The following is a description of a gene set: Human Gene Set: GOBP_DEFENSE_RESPONSE_TO_OTHER_ORGANISM species: Homo sapiens Reactions triggered in response to the presence of another organism that act to protect the cell or organism from damage caused by that organism., and this is the list of marker genes: TRIM54, IFNL1, DTX3L, NLRP1, DEFB108B, CNPY3, BPIFB1, UAP1, CXCL10 (C-X-C motif chemokine ligand 10), IRF7, NTS, SRPK1, ZBTB1, LRRC19, TRIM51, IGHA1, TRIML1, RAET1E (retinoic acid early transcript 1E), TNFSF4, HLA-E, GARIN5A, YTHDF3, CSF1, IL31RA, KYNU, SELP, METTL3, TRIM27, NPLOC4, HAVCR2, SMARCA5, CCL17, CCL11, SYT11, CCL24, S100A9, VIP, VPS26B, MIR19A, LEP, IFNK, SLAMF6, RFPL1, VGF, RAB27A, IFITM3, LGALS9, CD200, NLRC3, CXCL2, PGLYRP2, BIRC3, RAB20, GPR146, PGLYRP3, RNF34, IFNE, TRAFD1, INS, JAK2, FBXL2, TUSC2, TRIM64B, LILRB1 (leukocyte immunoglobulin like receptor B1), CCL21 (NCBI Gene Id 6366), CHUK, LPO, LCE3C, APPL2, POLR3F, CFH, CD160, KIR2DS2, WFDC3, MARK4, UNC13D (NCBI Gene Id 201294), CD6, N4BP3, IFNA7, MEFV, CCL27, ADAMTS4, CR1, AP3B1, TREM2, DEFB121, GBP1, IFITM2, C4BPA, C4B, PELI3, ACTG1, WFDC9, PTX3, CD300E, REG1B (NCBI Gene Id 5968), FCER2, IFNL3, BIRC2, OPRK1, TTLL12, ATAT1, HSPD1, EPRS1, ARHGEF2, SERPING1, FGL2, PPP2R3C, NCR3, ZDHHC11, ILRUN, CAMK2A, USP15, FOSL1, CDC42EP2, IFNA4, DDX3X (NCBI Gene Id 730543), NFKB1, DDX17, EIF2AK2, CADM1, TRAV27, ITGAX (integrin subunit alpha X), HCST, DEFB125, ATG5, CHGA, GBP3, CCL20, CAMP, RAB11FIP2, MICB, EP300, KLRF2, SCNN1B, NAGLU, USP17L2, GATA6, RAB14 (NCBI Gene Id 51730), HK1, KNG1, IL27RA, VAMP2, TRIL, RFPL2, FFAR2, TBK1, CD96, CCL8, CCL25, DDX56, EREG, LCE3B, LATS2, SERINC5, TYK2, XCL1, CREB3, CD300LF, TRIM4, SUSD4, CDC37, TMEM43, BECN1, ANXA3, RNF135, ELANE, UBE2N, HRAS, PUM1, TMEM33, LRCH4, HMGB1, CLEC4M, LATS1 (large tumor suppressor kinase 1), HERC5, XCL2, AGBL5, KLRB1, CCL3, PF4, PRSS3, HLA-DPA1, F12, MYD88, KLRG1, UBE2L6, PLEKHM2, IFIT5, CD2, TARBP2, IFI6, RNASE3 (NCBI Gene Id 6037), IFNA21, DRD2, JAK1, STAT5A, IL17RA, XRCC5, CPT1A, IRF1, CARD8, CXCL8, TRIM6, NLRP10, LYST, IL27, DEFB1, ARG1, GRAMD4, NCBP3, PLSCR1, SRPK2, FCN2, RFPL4A, DCST1, COTL1, PPT1, DAPK3, IFNW1, OAS3, SHFL, GPAM, RFPL4B, TRIM14, FADD, TRAF3IP2, INPP5D, TREX1, MAP3K14, TLR8 (toll like receptor 8), IFI27, ZMPSTE24, SLAMF8, TRIM43B, DEFB136, RPS6KB1 (ribosomal protein S6 kinase B1), STING1, SAMHD1, TIFAB, TRIM49B, IL21, UBE2W, NCBP1, CD55, MIR149, DEFB131B, GNLY, TNIP1, DDIT4, CRTAM, TOMM70, CDC42EP4, C1QB, FCRL3, TLR9 (toll like receptor 9), PIK3CB, ZMYND11, UBE2K, TRIM58, TRDV1, ULBP3, IL17RC, LAMP2, DEFB124, CEBPB, IKBKE, CD1D, MED1 (mediator complex subunit 1), CLEC4C (NCBI Gene Id 63328), MIR200B, TRIM7, C5AR1, RBM47, ADAM15, G3BP1, PRTN3 (proteinase 3), ZDHHC4, NLRX1, PIK3AP1, DEFB107B, DEFB114, KLRC4 (NCBI Gene Id 8302), BPI, IL36RN, MR1, ANG, VNN1, BNIP3L, TREM1, TRIM52, ABCC9 (ATP binding cassette subfamily C member 9), CD300C, PYDC1, TRIM55, IFNA10, OAS2, CXCL11, NMB, APOBEC3G, FCER1G, KLRC1, PLCG2, TRIM32 (tripartite motif containing 32), VAPB, APOBEC3A, PHB2, NQO1, CD274, IRF3, AXL, CLEC2A, CXCL12, NFKBIA, IPO7, GSDMC, LALBA, CX3CR1, CCL18, IGHG4, OGT, STXBP3, CYLD, AKAP8, PYCARD, CASP1, PAK3, CFP, DHX15, CR2, LGALS8, SQSTM1, SLC11A1, SLC15A3, TRIM40, S100A7, TRIML2, LYG2, SLAMF1, ACOD1, CD244, IFI44L, MNDA, DEFB129, ANKRD17, ZYX, IL15, IRAK3, PLAC8, DEFB131A, ZNF175, CFHR5, INAVA, CFB, IFNA8, VSIG4, H2BC10, LYPD8, LILRA5, ELP6, MX2, FOXP1, MUL1, TYRO3, PF4V1, OAS1, CD300A, MIR20A, TBKBP1, EDN1, TRIM25, CXCL1, LACC1, SIRPA, DEFB105A, FCGR3A, HLA-A, LGALS4, H2BC12, DEFB134, NLRP6, CD84, TRIM68 (NCBI Gene Id 55128), LEAP2, REG1A, TMEM120A, H2BC12L, CLDN1, NPPB, IFNA17 (NCBI Gene Id 3451), KIR3DL1, RPL39, REL, SPINK5, BCL2, GBP2, SMPD1, CXADR, VAMP4, TREML4, C4BPB, PTPRS, CCL7, PPBP, MST1R, TAC1, RIOK3, ZDHHC11B, DEFB135, STMP1, MAP2K6 (NCBI Gene Id 5608), STX8, DEFB110, CCL19, NCF2, AQP1, VAV1, ZDHHC5, SPAG11A, SMIM30 (small integral membrane protein 30), TRIM74, CFI, TRIM48, NOP53, TNFRSF1A, PRKDC, TUBB4B (NCBI Gene Id 10383), NCK1, MATR3, KLRC4-KLRK1, PIK3R1, GBP4, MAP3K7, AIF1 (allograft inflammatory factor 1), TYROBP, TRGV3, MAPK8, IL36A, MIR210, TRIM64, ZC3H12A, DNAJA3, PIK3CD, CASP8, PLA2G10, GPR108, TARM1, VAMP3, TRIM63, ERAP1, ZNFX1, GPR15LG, SLC9A9, CEP63, CGAS, KCNJ8, NLRC4, BST2, SEC14L1, NT5C3A, HSP90B1, TRIM35, CD58, SERPINB4, STAB2, PLPP6, RELA, POLR3D, IGHA2, LILRA4, HP, CORO1A, APOL1, KIF5B, UBD, MMP7, LRRC14, KLRF1 (killer cell lectin like receptor F1), PRF1, NLRC5 (NCBI Gene Id 84166), CRISP3, DNAJC3, TRIM61, IL23R, JCHAIN, CCL5, CXCL3, TLR6, MIRLET7I, C6, NEDD4, SFTPD, DUS2, MID2, KCNK6, CCL3L3, TRIM3, GBP7, CALCA, PYDC2, PMAIP1, CCL28, LCN10, APOBEC3F, LY6E, CLEC7A, AZI2, IFNA2, ARID5A, XIAP, PCYOX1L, RPL13A, RFTN1, HLA-C, PLA2G2F, C1RL, CASP4, WFDC13, CALHM6, PTPN11, NR1H3, IL36B, FGA, RNASEL, TRIM13, LYZL6, HDAC4, IFITM1, C1R, HSPA1B, CTSS, TGFB1, WFDC12, DEFA1 (defensin alpha 1), RNASE12, HEXIM1, POLR3G, CX3CL1, CD209, ATG12, MIF, ADM, ZNRF1 (NCBI Gene Id 84937), TASL, MAVS, IFI35 (NCBI Gene Id 3430), PRKCD, ENDOD1, ADAM8, RBCK1, MRC1, SIGLEC10, SP100, RAG2, PARP1, TSLP, RNF216, PPP6C, PUM2, FLOT2, TRIM50, MIR140, PPP1R14B, DEFB104A, SFPQ, RASGRP1, SLC30A8, ZDHHC12, VIM, RAB43, SEMG1, TRIM26 (tripartite motif containing 26), DEFB108A, RNF170, TRIM77, WASHC4, SKP2, DEFB130A, IL33, PTPN2, DEFB4A (NCBI Gene Id 1673), IL1B, UBA7, RTN4, RNASE2, PELI1, FPR2, DEFB109B, NFE2L2, CLEC6A, EPG5, CFD, CASP7, NFKBIL1, CLEC12B (C-type lectin domain family 12 member B), MIR520B, GKN2, FLOT1, SERPINE1, TRIM65, TREML1 (triggering receptor expressed on myeloid cells like 1), LY86 (NCBI Gene Id 9450), USP44, RNASE13, WFDC10A, HMGB2, TOR2A, ADAMTS5, MPO, CTSG, NCR1 (natural cytotoxicity triggering receptor 1), LRSAM1, CSF1R, MMP12, POLR3E, DEFB103A, DEFB116, ITCH, LY96, LCN2, TRIM5, LSM14A, NLRP4, RPS6KA3, PARP14, UFD1, CXCL9, STX4, CEBPG, TRIM49C, PJA2, ARRB2, HLA-F, CCL16, KLK7 (kallikrein related peptidase 7), PARP9, CYP27B1, ATG7, JAGN1, ATG9A, IFNB1, STATH, SPN, TMEM106A, TSPAN6, PADI4, SIN3A, LYG1, DAPK1, H2BC6, TRIM49, YWHAE, CYBB, CCL23, SIGLEC16, NPY, PI3, EXOC1, AIM2, SLC30A1, TRAF6, SELENOK, PGC, KRT16, KAT5, CCL4, ELMOD2, ATP1B1, IFNA6, POLR3C, SPSB3, DEFB106B, GSDMB, DEFB128, HCFC2, DEFB133, ULBP2, MLKL, HSPA8, CD36, SARM1, MASP1, ITGAM (NCBI Gene Id 3684), EMILIN2, SLC15A4, CRK, PYDC5, RNASE8, PSTPIP1 (NCBI Gene Id 9250), H2BC4, TLR10, P2RX7, SDHAF4, S100A12, CD40, NEURL3, ATAD3A, CITED1, GZMM, MIR26B, EVPL, TNIP2, SNX3, DEFA4, PIK3R6, RARRES2, TRGV8, LRRC15, EPPIN, MFHAS1, IFNL2, SCARA3, IFNG, LYZ, CASP6, CST11, BANF1, GZMB, NR1D1, TRIM22, PDE12, IRF5, TMEFF1, VAMP7, RIPK3, IFI16, TNFAIP3, IFIT1B, RFPL4AL1, C8G, TRIM23, IFNA1, TFEB, CYBC1, MMRN2, DEFB126, TRIM11, TTC4, DHX36, USP38, ZDHHC18, ZCCHC3, DEFB127, CD37, CD226, RNASE7, CD177, IL1RL2, ACTR3, CXCL5, FCAR, APOBEC3D, PLA2G2A, SRC, SPAG11B, MASP2, MMP3 (NCBI Gene Id 4314), CALCOCO2, BSPRY, NKG7, HTN3, AKAP1, TRAF3, C1QA, XRCC6, TRIM29, TUBB, BNIP3, HYAL2, RAET1G, POLR3H, GFI1, CCL15, H2BC8, ARG2 (NCBI Gene Id 384), POLR3B, USP27X, IL1RAP, TRIM49D1, MOV10 (Mov10 RNA helicase), NOD2, BRCC3, ZDHHC1, RNASE1, IL6R, MIR520E, TRIM44, H2BC21, TF, MAPKBP1, LCE3A (NCBI Gene Id 353142), IRGM, TRIM72 (tripartite motif containing 72), NLRP9, ADAR, CPTP, RNF31, ISG15, STAT2, PTPN6, PQBP1, CXCL14, CLNK, DEFA1B, STXBP2, CD14, MIR17, C5, CST9LP1, RIPK2, RAF1, TMEM126A, CH25H, HMGN2, WFDC5, CD207, DEFB118, LGALS3, FOSL2, APOBEC3B, KLK3, TRIM49D2, RBPJ, ZG16, HPX, PTPRC, NONO, CXCL16, IL12A, RAB7B, IKBKB, TKFC, PLA2G5, ALPK1, MARCO, GSDMA, SLC22A5, PCBP2, HMGB3, ANXA1, SCIMP, DEFB103B, SPIRE1, EIF4E2, CLEC4A (NCBI Gene Id 50856), DTX4, MIR4691, TNFSF8, TRIM15, CLEC4E, DDX60, CD300H, IL6, LBP, BPIFB3, TRIM75, DUSP10, USP14, LY9, KLRK1, BATF, DDX39A, PGLYRP1, OTUD4, GRB2, KRT1, IFNA16, RNF125, ACP5, MIR21, CXCL6, LYAR, F2RL1, SETD2, NMI, DEFB107A, RNASE6, ADAM17, GSDMD, DEFB115, KLRC2, EXOSC5, BATF2, NR1H4, MARCHF5, SFN, GPS2, PRDM1, PVR (NCBI Gene Id 5817), CLEC5A, DDX41, FOXP3, PRSS2, RNF185, DEFB106A, TAB2, LILRA2, STXBP4, RNASE10, AURKB, BPIFA2, TXK, EMILIN1, TRIM41, IL22RA1, ULBP1, NEK7, DEFB105B, TRIM59, PYHIN1, MIR181B1, ECSIT, CD47, ERCC6, FGB, TICAM1, HSP90AA1, C1S, CLPB, N4BP1, KLRC3, AKT1, DEFA3, ABCF3, S100A8, CNOT7, PAK1 (p21 (RAC1) activated kinase 1), CYBA, FCN3, SHARPIN, CCL14 (C-C motif chemokine ligand 14), IL18RAP, USP20, SEH1L, HLA-B, CLEC4D, WNT5A, CFHR1, SEMG2, IL17F (NCBI Gene Id 112744), DCD, RNASE9, MIRLET7B, TRIM43, CCDC88B, OASL, NINJ1, PLD4, TRAF2, AIMP1, HVCN1, TRAF3IP3, PPP2CA, CRIPTO, FBXO9, CCL13, IFNL4, IGHG1, PGLYRP4, RSAD2, IL10RB, AKIRIN2, H2BC11, OPTN, USP29, TSPAN32, IGKV3-20, MYO1C, TLR5, UBL7, IFNLR1, PDPK1, PTPN22 (protein tyrosine phosphatase non-receptor type 22), CRP, GDI1, GSN, PPM1B, LRP8, NT5C2, TRGV5, BCL2L1, COLEC11, NUB1 (negative regulator of ubiquitin like proteins 1), PLA2G6, CDC42, SENP7, GPATCH3, C7, MAP4K2, TRIM21, MPEG1, TANK (NCBI Gene Id 10010), MUC7, MSRB1, FCGR1A, RPSA, HRG, DDX21, IKBKG, NDUFAF4, NLRP2, IL10, SYNCRIP (synaptotagmin binding cytoplasmic RNA interacting protein, NCBI Gene Id 10492), HSPA1A, ZNF697, TRIM38, POLR3A, RPS19, TRIM10, LGR4, TNFAIP8L2, IFNGR1, AP1G1, APP, CCL22, NLRP2B, GATA3, IRF4, NOS2, MIR200C, MAPKAPK2, IGHD, TLR2, SERPINB9, IFIT2, NECTIN4, KLRD1, MIR146A, TRIM8 (NCBI Gene Id 81603, tripartite motif containing 8), PRKD1, CHMP3, PAK2, IL7R, TNIP3, GALP, IFNA14, DMBT1, TRIM64C, APCS, FGR, USP18, C4A, STAT5B, REG3G, TRIM60, BCL10, IFNAR2, OTULIN, SLC15A2, DEFB123, GCH1, DHX33, TRIM31, COLEC10, DHX9, SLC26A6, DEFB104B, LYN, SERINC3, NFKBIZ, LYZL4, C9, YTHDF2, APOA4, IRF2, IL36G, PRKCE, ROMO1, GRN, IFNGR2, C1QC, CCDC92, PRKRA, RTP4, CCL4L2, NAGK, WRNIP1, JAK3, CD46, STAB1 (stabilin 1), IRAK4, IL18, YWHAZ, GAPDH, IRF9, TRIM17, HTN1, CD180, LTF (lactotransferrin), SH2D1A, TMED1, ATG16L1, IGHE, SLFN13, CCL2, BTK, SLFN11, WAS, PPP1R11, TRAF4, APOBEC3C, EPHA2, SHMT2 (serine hydroxymethyltransferase 2), CCL26, CHID1, EPX, RNF213, SPON2, AQP4, SAMD9, AGBL4, RELB, SPRR2A, RNASE4, CEACAM1, MX1, PIM1, NOTCH2, WDFY1, UBQLN1, AARS2, F2, IL12B (interleukin 12B), NCF1, DAO, LTA, RIGI, PLA2G1B, ERBIN, RNF115, DEFA5 (NCBI Gene Id 1670), SLAMF7, FYN, ILF3, C3, ARMC5, RAB2B, PHB1, LAG3, CXCL13, STAT1, IGHM, APPL1 (NCBI Gene Id 26060), ABHD17A, DHX58, NR1H2, TNFRSF14, KLK5, G3BP2, TRIM51G, CIITA, SNCA, CCDC134, TRGV2, PPARG, APOE, ADAMTS13, DDX1, IFIT3, RB1CC1, RNF19B, PIK3CG, DDX60L, H2BC7, C1QBP, DEFB132, BPIFC (BPI fold containing family C), DAB2IP, IL23A, CFHR2, SLC46A2, BPGM, ADGRB1, COLEC12, IFIH1 (NCBI Gene Id 64135), C8B, NMBR, NECTIN2 (nectin cell adhesion molecule 2), SSC5D, HLA-G, IGHG3, MAPK3, C8A, TICAM2, CD4, CLU, SEC61A1, PRG2, EIF2AK4, TIRAP, SMPDL3B, TRDV3, MICA, RNF144A, TAB3, IPO5, TAX1BP1, TMEM45B, PTPN1, DEFB112, B2M, LYPLAL1, IFNA5, CALM1, TRIM62, SH2D1B, GP2 (glycoprotein 2), BCL3, ASS1, IFNAR1, TMF1, ISG20, EXOSC4, NAIP, CLDN2, POLR3K, TAB1, MCOLN2, GBP6, SMPDL3A, ZDHHC3, IFIT1, MALT1, CLEC10A, CCL1, TLR1, DEFB119, DHX16, ATG14 (NCBI Gene Id 22863), ARL8B (ADP ribosylation factor like GTPase 8B), TLR4, AICDA, NRROS, TRAF3IP1, FAU, KIR2DL4, LACRT, SHC1, PRDX1, TIFA, HCK (NCBI Gene Id 3055), CST9L, STXBP1, ABHD8, DEFB130B, RPL30, TRGV9, IL4R, MARCHF2, FASLG, TRIM73, RAB1A, RASGRP4, WFDC11 (WAP four-disulfide core domain 11), WFDC2 (NCBI Gene Id 128489, WAP four-disulfide core domain 2), SYK, GIGYF2, SLC19A1, MAP3K5, ACTR2, ESR1, ZNF683, ANKHD1, C2, IL17A, PRB3, MAPKAPK3, POMC, TRDV2, RDUR, IRAK2, TRIM39, MIR708, RNASET2, ZBP1, RNF39, GPER1, TNF, KCNK13, SIRT2, VAMP8, MBL2, APOBEC3H, RNF166, CSNK1A1, MIR223, HDAC6, IL12RB1, SPI1, UNC93B1 (NCBI Gene Id 81622), DROSHA, RBM14, RNASE11, FAM3A, BPIFA1 (BPI fold containing family A member 1), SLPI, FCGR2B (NCBI Gene Id 2213), TRIM28, TRIM69, MORC3, NLRP3, PML, IRF8, REG3A, GBP5, CACTIN, TIGIT, USP50, DEFB113, ADARB1, TRIM34, A2M, IRAK1, TP53, UMOD, LETMD1, ZNRF4, TOLLIP, RNF26, FLNB, TLR7, CST9, MIR758 (microRNA 758), TLR3, IGHG2, KRT6A, PSPC1, CRCP, LAMP1, WFDC10B, CD74, IL34, CAV1, TRIM56, S100A14, CARD9, AZU1, RFPL3, DEFA6, OTOP1, CREBBP, NOD1, HAMP, FCN1, ZC3HAV1, TRGV4, ZDHHC9